The following is a description of a gene set: Reactome Pathway: Ion channel transport Ion channels mediate the flow of ions across the plasma membrane of cells. They are integral membrane proteins, typically a multimer of proteins, which, when arranged in the membrane, create a pore for the flow of ions. There are different types of ion channels. P-type ATPases undergo conformational changes to translocate ions. Ligand-gated ion channels operate like a gate, opened or closed by a chemical signal. Voltage-gated ion channels are activated by changes in electrical potential difference at the membrane. part of: Transport of small molecules species: Homo sapiens, and this is the list of marker genes: ATP1B1, TRPV6, ANO5, TRPM7, CLCN7, TRDN, TRPM5, OSTM1, ATP6V1A, ATP10A, ATP6V1G3, ATP2B3, SGK3, ASPH, TRPA1, ANO10, CASQ1, RIPK3, ATP8B4, NALCN, ANO9, CLCN5, ATP13A2, UBB, TRPC6, CLCNKB, ATP7A, CLCA2, TRPC5, ATP2A1, ATP6V0C, FXYD6 (FXYD domain containing ion transport regulator 6), BEST3, RYR3, RPS27A, UNC79, BEST2, ATP2C2, ATP4A, ATP2A3, ATP13A4, ATP6V1B1, TRPM2, ATP6V0A2, BSND, ATP11B, SCNN1D, ATP1B2, RYR2, ATP1A3, ATP7B, ATP2B2, SCNN1G, SGK1, TRPC1, TTYH1, WNK3, PLN, CLCN6, TRPV5, PDZD11, ATP8A2, ATP8B2, ATP6V1F, ANO7, WNK1, ASIC1, CALM1, ATP6V1E1, TTYH2, ATP2B4 (NCBI Gene Id 54594), CAMK2B, ATP11A (ATPase phospholipid transporting 11A), RAF1, ATP6AP1, ATP9B, WNK2, TRPM1, MCOLN2, CLCA4, ATP1A1, SLC17A3, FXYD1 (FXYD domain containing ion transport regulator 1), FXYD3, ANO8, ATP6V0E1, CAMK2G, CLCN1, FKBP1B, MCOLN1, NEDD4L, TRPM8, ATP8B3 (NCBI Gene Id 57203), TRPC3, CAMK2A, SLC9C2, ATP6V1C1, ATP13A5, ANO6, ATP6V0B, ASIC3 (acid sensing ion channel subunit 3), FXYD4, SCNN1B, FXYD2, TRPC4AP, MLKL, CLCN4, STOML3, UBA52, ATP6V1D, ATP6V1C2, ATP1B3, RYR1, ATP1A4, TCIRG1, ATP2B1, TRPM6, BEST4, TSC22D3, ATP6V1E2 (NCBI Gene Id 90423), ATP8A1, SLC9B2, CLCA1, TPCN1, SGK2, SCNN1A, ATP1A2, TRPC4, ATP6V1G1, ATP12A, BEST1, ATP6V0A1, TPCN2, ATP6V0D2, ATP10B, ATP2A2, ATP10D, TRPV3, ASIC2, FXYD7, TTYH3, ATP6V0D1, CAMK2D, TRPV4, RIPK1, TRPV1, ATP13A1, CLCN2, TRPV2, ATP4B, ASIC5, TRPM3 (NCBI Gene Id 80036), ANO2, CASQ2, ANO3, ATP11C, TRPC7, CLCN3, ATP6V1B2, SRI, UNC80, SLC9C1 (NCBI Gene Id 285335), CLCNKA, ASIC4, CUTC, CLIC2, WNK4, UBC, TRPM4, ATP6V1G2, ATP6V0A4, ANO4, SLC9B1, ATP6V1H, ATP6V0E2, STOM, ATP2C1, SLN, ANO1, ATP9A, ATP8B1 (NCBI Gene Id 5205), WWP1, MCOLN3